The following is a description of a gene set: Regulatory T cells (Tregs) play a critical role in the maintenance of immunological self-tolerance. Naïve human or murine T cell treatment with the inhibitory cytokine IL35 induces a regulatory population, termed iTR35, that mediates suppression via IL35, but not IL10 or TGFβ, neither express nor require Foxp3, are strongly suppressive in five in vivo models, and exhibit in vivo stability. Treg-mediated suppression induces iTR35 generation in an IL35- and IL10-dependent manner in vitro, and in inflammatory conditions in vivo in Trichuris-infected intestines and within the tumor microenvironment, where they appear to contribute to the regulatory milieu. iTR35 may constitute a key mediator of infectious tolerance and may contribute to Treg-mediated tumor progression, and ex vivo-generated iTR35 may possess therapeutic utility. Genes up-regulated in control T conv versus resting T reg cells. Human Gene Set: GSE24210_TCONV_VS_TREG_UP studied in species Homo sapiens from publication Collison LW, Chaturvedi V, Henderson AL, Giacomin PR, Guy C, Bankoti J, Finkelstein D, Forbes K, Workman CJ, Brown SA, Rehg JE, Jones ML, Ni HT, Artis D, Turk MJ, Vignali DA (PMID 20953201), and this is the list of marker genes: KLHL6, NXPE2, TEX29, RGS2, MYL12B (NCBI Gene Id 103910), LRFN5, LTK, PAPLN, COPG2IT1, MON2, FDPS, SAMD10, GMDS, SORL1, MANF, FOXA1, LPAR6, CERT1, EPX, KRT34, RAPGEFL1, TBL1XR1, P4HTM (NCBI Gene Id 54681), EGFR, RNF187, DES, LTO1, IGSF8, PCP4, CD82, TMEM74B, MGRN1, SUSD3, XBP1, TM6SF1, MZT2B, PAG1, LYZL4, PPFIA3, USP13, MACC1, CYP4A22, SMCO3, PPP1R18, PROB1, PARP16, PLPP1, GRHL3, LYSMD1, CDC42EP1, NUDT18, LY96, PKP3, COX4I2, HAVCR1, CPTP, SSH1, SUB1, SIK2 (salt inducible kinase 2), LENEP, PLD3 (NCBI Gene Id 23646), TNFSF11, PROM1, SC5D, F2RL1, MND1, CLEC11A, PPIC, GSN, ERP44, B3GNT2, SIT1, PLS1, PTTG1, NCS1, SERPINA11, PSD4, PIPOX, BLVRA, KCTD10, TRPC5, ASB17, TMEM126A, CAPNS1, ITPRIP, CEACAM21, ZNF157, SEPTIN9, PSAT1, RAP1GDS1, GSTA3, SAMD12, ATP6V1G1, DAB2IP, GATM, USO1, METTL24, CA13, TMEM132A, SPSB2, CFHR1, ELOVL7, VEZF1 (vascular endothelial zinc finger 1), SLC46A3, TMEM18, BSPRY, FARP2, RGS13, ITGB7, DIXDC1, JCHAIN, EZR, ZNF248, SERPINE2, NAGA, HOXD1, BCL2L2, CTSB, SLBP, PADI2, EGF, HOPX, DNAJB5, SMAGP, ZNF239, AKAP6, HMG20A (high mobility group 20A), KRT26, ACAP1, ITPR3 (NCBI Gene Id 3710), DENND11, SCAMP1, RAP1GAP2, TEKTL1, LMO2, RHD, SMCO1, PRICKLE1, PADI4 (peptidyl arginine deiminase 4), UQCRQ, CCIN, ACOX3, NYNRIN, RHBDF1, PDLIM2, PRDX6, HK1, MEOX2, SELENON, CR2, SLC35D2, DYRK3 (NCBI Gene Id 8444, dual specificity tyrosine phosphorylation regulated kinase 3), RCAN3, PGLS, RFX5, PHF1, GYG1, TEC, SLC41A2 (solute carrier family 41 member 2), DHRS7, ELMOD1, PMVK, COMMD5, PRR36, KLK12, FMNL3, EDEM1, LINC01160, F2RL2, GPX4, LYL1, SGCE, B4GALT1, EPHX4, ARID3B, XYLB, ATG9A, NEDD4, MAP3K14, TMEM192, PTPRE, PIGP, MFSD10, RIPK3, MCUB (NCBI Gene Id 55013), SELENOH, NFATC1, PPP3CC, TPRG1, RP9, FBXL4, SH3BGRL3, MAP4K1, ZNF35, MYO7A, SCD, MAK, RDH5, VEGFC, MTA3